Given this list of marker genes SHOX2, RTN4, LRRK2, BCL11A, MAP3K13, here is a description of the gene set: Any process that modulates the frequency, rate or extent of branching morphogenesis of a nerve. Human Gene Set: GOBP_REGULATION_OF_BRANCHING_MORPHOGENESIS_OF_A_NERVE species: Homo sapiens